The following is a description of a gene set: part of: TCF dependent signaling in response to WNT electronically inferred by orthology from the curated human pathway species: Mus musculus This event has been computationally inferred from an event that has been demonstrated in another species.<p>The inference is based on the homology mapping from PANTHER. Briefly, reactions for which all involved PhysicalEntities (in input, output and catalyst) have a mapped orthologue/paralogue (for complexes at least 75% of components must have a mapping) are inferred to the other species. Reactome Pathway: Deactivation of the beta-catenin transactivating complex, and this is the list of marker genes: Rps27a, Tcf7l2, Sox4, Sry, Ubb, Sox7, Xpo1, Ctnnb1, Cby1, Sox17, Chd8 (chromodomain helicase DNA binding protein 8), Tcf7, Tcf7l1, Sox2, Sox6